Given this list of marker genes Gm5134, Hmgcl, Zfp36l2, Sgms1, Ldhd, P2ry10b, here is a description of the gene set: Genes predicted to be targets of miRBase v22 microRNA mmu_miR_1306_3p in miRDB v6.0 with MirTarget v4 prediction scores > 80 (high confidence targets). from publication Chen Y, Wang X (PMID 31504780) studied in species Mus musculus Mouse Gene Set: MIR_1306_3P